Given this list of marker genes CYP2C9, CYP2J2, CYP2C8, CYP3A7, CYP4B1 (NCBI Gene Id 1580), CYP1B1, CYP2C19, CYP2D6, CYP2C18, CYP2E1, CYP2B6 (NCBI Gene Id 82059), CYP1A1 (NCBI Gene Id 1543), CYP3A4, CYP11A1, here is a description of the gene set: Cytochrome P450. Human Gene Set: MODULE_106 studied in species Homo sapiens